Given this list of marker genes ESRP1, KRAS, POU3F4, LZTR1, PEX6, FOXP2 (NCBI Gene Id 93986), CEP78, OTX2, MRAS (NCBI Gene Id 654181), KCNJ10, KARS1, SOS1, CIB2, ERF, PRRX1, USH2A, USH1G, POLR1B, SIX5, SEMA3E, THOC1, GJB6, ORC1, PDCD10, AHDC1, SIX1, KRIT1, POLR1D, SOS2, MYO7A, KDM6A, COL4A6, FGF3, FGFR3, SRCAP, NEUROG1, ADGRV1, RASA2, ANKH, NDP, GJB2, ESPN, DDX11, SETBP1, EYA1, SALL4, SLC26A4, SOX10, CDH23, CHD7, USH1C, CBL, HRAS, FOXI1, HAAO, VHL, COQ6, CCM2, RRAS2, PI4KB, PCDH15, POLR1C, CHN1, EBF3, CLRN1, SPRED1, AIFM1, TRRAP, ABCC1, TWIST1, USP48, FGFR2 (NCBI Gene Id 2263, fibroblast growth factor receptor 2), RRAS, RIT1, AKT1, MAFB, TP63, TIMM8A, PTPN11, NF2, RAF1, MAP3K7, COCH, NRAS, KMT2D, GREB1L (NCBI Gene Id 80000), MT-TS2, PIK3CA, CCDC50, ARSG, HARS1, SMARCB1, WHRN, TCOF1, SPRED2, PDZD7, CCND1, here is a description of the gene set: Abnormality of the inner ear studied in species Homo sapiens An abnormality of the inner ear. Human Gene Set: HP_ABNORMALITY_OF_THE_INNER_EAR